The following is a description of a gene set: species: Homo sapiens Human Gene Set: REACTOME_COOPERATION_OF_PREFOLDIN_AND_TRIC_CCT_IN_ACTIN_AND_TUBULIN_FOLDING Cooperation of Prefoldin and TriC/CCT in actin and tubulin folding, and this is the list of marker genes: CCT7, TUBA4A, CCT6B, TUBB2A, TUBB2B, PFDN2, TUBA3D, CCT5, CCT3, VBP1, PFDN5, TUBA1C (tubulin alpha 1c), TUBA3E, ACTB (NCBI Gene Id 60), CCT2, PFDN1, TUBB3, CCT8, TUBA4B, CCT4, TUBB6, TCP1, TUBAL3, TUBB4A (tubulin beta 4A class IVa), TUBA3C, PFDN4, TUBB1, CCT6A, TUBA1A, TUBA1B, PFDN6, TUBA8, TUBB4B